The following is a description of a gene set: species: Mus musculus Transport of the SLBP Dependant Mature mRNA Mouse Gene Set: REACTOME_TRANSPORT_OF_THE_SLBP_DEPENDANT_MATURE_MRNA, and this is the list of marker genes: Rae1, Ranbp2, Nup155, Tpr, Seh1l, Nup214, Nup160, Slbp, Ncbp1, Nup107, Nup37, Ncbp2, Nup35, Alyref, Nup85, Nup54, Nup133, Nup43, Nup58 (NCBI Gene Id 71844), Ndc1, Nup50, Nup210, Sec13, Nxf1 (nuclear RNA export factor 1), Nup62, Nup42, Eif4e, Nup98 (nucleoporin 98), Nup205, Nup88, Aaas, Nup153, Nup188, Pom121, Nup93